Given this list of marker genes DAPL1, MIR223, PAIP2B, IGF2BP3, MIRLET7B, DHX29, MIR639, MIR758, MIR187, MIR127, MIR219A1, MIR650, MIR326, MIR486-1, MIR638, PURA, CNBP, AIRE, MIR30C1, MIR10A, MIR573, MIF4GD, ACO1, MIR365A, MIR345, MIR153-1 (microRNA 153-1), IGF2BP1, MIR125B1, MIR6086 (NCBI Gene Id 102466519), MIR423 (microRNA 423), MIR376C, MIR1181, DHFRP1, MIR149, MIR29B1, MIR210, MIR520D, DAZ2, MIR218-1, MIR509-1, MIR301A, MIR708 (NCBI Gene Id 100126333), MIR663A, MIR640, FXR2 (FMR1 autosomal homolog 2), TRIM71, MIR29A, CIRBP, MIR202, MIR103A1, MIR1277, MIR29C, MIR876, MIR9-1, MIR106A, MIR335, MIR185, MIR200B, MIR125A, MIR3619, MIR455, MIR105-1, MIR28, MIR497, MIR517A, PTENP1-AS, MIR92B, HHEX, MIR128-1, MIR107 (microRNA 107), MIR135A1, RACK1, MIR20A, MIR4691, MIR15B, MIR135B, MIR203A, MIR515-1, MIR939, MIR657, MIR195, MIR503, MIR548P, MIR3148, MIR5588, MIRLET7A1, MIR181B1, MIR588, MIR27A, MIR27B, MIR224, MIR564, MIR6869, MIR514A1, SERBP1, MIR19A, MIR892B, MIR551A, MIR451A (NCBI Gene Id 574411), MIR1224, MIR328, MIR483, MIR183, MIR2355, MIR143, MIR383 (NCBI Gene Id 494332), MIR4500, FMR1, MIR188, MIR148B, MIR655, MIRLET7E, MIR767, SHMT1, PAIP1, MIR148A, MIR362, EIF4EBP3, MIR130A, MIR24-1 (NCBI Gene Id 407012), ABCF1, EIF2AK3, ZNF540, MIR26B, MIR130B, CYFIP1, MIR146B, MIR885, MIR196A1, MIR518A1, MIR499A, MIR1260B, DAZ1, NEURL1, MIR4286, MIR93, MIR520E, ZCCHC13, MIR145, MIR339, MIR136, MIR150, MIR302C, MIR526A1, MIR208A, MIR133A1, DAZ3, MIR200A, MIR221, MIR142, MIR562, MIR96, MIR625, MIR194-1, MIR106B, MIR10B, MIR146A, MIR490, MIR101-1, MIR21, MIR517C, MIR340, MIR454, MIR518C, MIR409, MIR301B (NCBI Gene Id 100126318), MIR193B, MIR4516, LARP1, MIR520H, MIR302D, MIR30A, MIR298, MIR19B1 (NCBI Gene Id 406980), MIR18A, RPS27L, MIR30C2, MIR572, MIRLET7C, MIR4632, MIR137, MIR1908, MIR372, MIR935, DAZ4, MIR874, MIR661, PAIP2, CELF4, IFRD2, MIR205, MIR1298, MIR22, RPS14, MIR23A, MIR320A, CTIF, MIR3173, MIR1246, RPS9, MIR607, MIR548D1, MIR133B, MIR193A, EIF4EBP2, MIR15A (NCBI Gene Id 406948), MIR99B, MIR877, SAMD4B, MIR505, MIR379, MIR26A1, MIR141, MIR299 (NCBI Gene Id 407023, microRNA 299), MIR154, MIR204, MIR152, MIR582, MIR485, MIR346, MIR126 (NCBI Gene Id 406913), MIR214, MIR548C, MIR129-1, MIR20B, MIR519E, MIR508, MIR92A1, MIR186, MIR181C, MIR222, MIR675, CPEB2, MIR200C, MIR151A, MIR543, MIR425, MIR608, MIR199B, MIR363, MIR374A, DAZL, MIR103B1, MIR34B, MIR501, MIRLET7I, MIR491, MIR32 (microRNA 32), MIR134, BOLL, MIR33A, MIR192, MIR132, MIR644A, MIR659 (NCBI Gene Id 724029), MIR654, MIR920, MIR520C, MIR449A, MIR144, MIR411, MIR371A, MIR488, MIR448, MIR665 (NCBI Gene Id 100126315), MIR1271, MIR30E, MIR1-1, MIR873, CPEB1, PURB, MIR544A, MIR487B, CPEB4, MIR519B, IREB2, SAMD4A, RPL10, MIR215, CELF1, MIR147A, MIR361, MIR498, MIR519D, MIR217, MIR182, MIR140, MIR34C, MIR613, TYMS, MIRLET7G, MIR211, MIR155, MIR519A1, MIR296, MIR181D, NANOS1, MIR1207, MIR16-1, MIR4686, MIR769, RARA, MIR18B, MIR17, IGF2BP2, MIR520B, MIR199A1, MIR494, MIR3909 (NCBI Gene Id 100500826), MIR3661, MIR191 (microRNA 191), MIR493, MIR323A, MIR34A, MIR99A, DHFR, MIR378A (microRNA 378a), MIR138-1, MIR208B, MIR190B, MIR30D, MIR590, MIR330, MIR373, MIR302B, MIR495, MIR520A, PABPC1, MIR181A2, EIF4EBP1, MIR511, MIR492, MIR139, MIR342, MIR329-1, MIR338, MIR30B, MIR424, FXR1, MIR552, MIR374B, MIR98, CPEB3, MIR33B, MIR212, MIR302E, MIR337, MIR206, MIR410, MIR302A, MIRLET7F1, MIR506 (microRNA 506), MIR25, MIR384, MIR518B, MIR100, PRKCH, MIR31, MIR429 (NCBI Gene Id 554210), here is a description of the gene set: Any molecular function involved in the regulation of initiation, activation, perpetuation, repression or termination of polypeptide synthesis at the ribosome. Human Gene Set: GOMF_TRANSLATION_REGULATOR_ACTIVITY studied in species Homo sapiens